Given this list of marker genes CCL21, SERPINE1, CRK, PTK2, CRKL, MUC1, IFT74, PIK3CG, WNK1, ADA, CYP1B1, ACER2, PTPN11, TESC, NCKAP1L, RAC3, LIF, LYN, PLAU, LPXN, ITGB1BP1, ITGB3, FOXC2, CIB1, PIEZO1, RET, P2RY12, DPP4, SKAP1, SNAI2, CXCL13, SFRP2, PODXL, EPHA8, CCL5, PTPN6, HRG, EFNA1, SYK, CD3E, ADAM9, NEXMIF, EPHA2, PDE3B, SWAP70, JAM3, FERMT1, TGFB2, FERMT3, here is a description of the gene set: Any process that modulates the frequency, rate, or extent of cell adhesion mediated by integrin. Human Gene Set: GOBP_REGULATION_OF_CELL_ADHESION_MEDIATED_BY_INTEGRIN species: Homo sapiens